The following is a description of a gene set: Human Gene Set: MIR4646_5P studied in species Homo sapiens Genes predicted to be targets of miRBase v22 microRNA hsa-miR-4646-5p in miRDB v6.0 with MirTarget v4 prediction scores > 80 (high confidence targets). from publication Chen Y, Wang X (PMID 31504780), and this is the list of marker genes: BBX, MANEAL, PCBD1, ZBTB20, SEPTIN6, LYN, AFF4, GAS7, GFPT1, ORAI2, RAVER2, METTL21A, VPS26C, ZNF547 (NCBI Gene Id 284306), SORD, FAM118B, CLASP2, CDH3, STEAP4, GRM5, KCNE4, ADRA2B, NXPH3, INO80D, MS4A6A, CNDP2, COL6A3, IFT70B, HS3ST3A1, ANGPTL2, MARCHF6, TIMP3, CDC23, PMM1, TBC1D16, HDGFL3, ABHD2, MTCL2, NECTIN1, PCDHB7, CCAR1, BNC1, RGS16, DCUN1D1, HCCS, PLEKHA5, NR3C1, SEL1L, DCTN4, METAP1, GGT7, HIC2, PDK3, FSHR (follicle stimulating hormone receptor), AGO3, ATOSB, LRATD2, ZNF544, GDAP1L1, COPG2, NIN, TBL1XR1, FPGT, COQ10A, FAM161B, FAXC, NEMF, ERICH1, PAX7, VANGL2, SPOCK1, AOPEP, LPCAT2, C21orf91, SLC5A3, RFT1, DESI1, GCK, ATP8B1, ARL8B, KLHL18, CACNA1C, PALM, STXBP5L, CCDC97, B9D1, LHFPL5, TGFBR1, CFLAR, SLC6A11 (solute carrier family 6 member 11), FSD2, MTFR1L, NFASC, FABP7, CDH7, CYP2E1, WDR31 (WD repeat domain 31), ZNF576, ACVR2B (NCBI Gene Id 93), SMIM7, CUL3, ICOSLG, EPHA3, ETS1, FAM168A, ITGB8, BAP1, ZMYND12, MOB3B, CARD17P, IRF2, COLGALT2 (NCBI Gene Id 23127), ZNF670, KATNIP, CPEB1, KIF1B, HLA-DQA1, GABBR2, DDX31, CCNT1, AAK1, GABRA5, TSEN34, N4BP1, KCNE1, ALG2, FAM120C, NEUROG2, BAHD1, SLC7A14, TOMM20, UNG, AGAP1, XYLT1, FN1, KPNB1, HSD17B8, PDE8A, ARHGEF33, C19orf44, TAF7, SUSD5, RORA, FRMD5, FOXN1, ADGRG7, POFUT1, ARFGEF3, ZNF70